The following is a description of a gene set: Any process that activates or increases the frequency, rate, or extent of cytokine production that contributes to an immune response. studied in species Mus musculus Mouse Gene Set: GOBP_POSITIVE_REGULATION_OF_CYTOKINE_PRODUCTION_INVOLVED_IN_IMMUNE_RESPONSE, and this is the list of marker genes: Rigi, Ticam1, Mavs, Tirap, Ifng, Inava, Slamf1, Card9, Klrh1, Tlr7, Malt1, Dhx36, Myd88, Cd36, Arid5a, Traf2, Cd55, Il21, Mapkapk2, Gata3, B2m, Cd55b, Clnk, Trim6, Kit, Tlr3, Laptm5, Cd226, Lacc1, Sash3, Cd160, Spon2, Traf6, Il4 (NCBI Gene Id 16189), Wnt5a, Ffar3, Casp1, Clec7a, Nod2, Nod1, Tbx21, Gprc5b, Cd81, H2-M3, Mif, Casp4, Scimp, Il18, Ddx1, Plcg2, Cd74, Il18r1, Psg22, Irf5, Tek, Nr4a3, Xcl1, Rtn4, Nlrp3, Gimap3, Syk, Fzd5 (frizzled class receptor 5), Tlr4, Tnfrsf14, P2rx7, Fcer1g, Panx1, Il6, Mir324, Map3k7, F2rl1, Ffar2, Sirt1, Il1b, Tlr2, Prkcz, Gimap5, Sema7a, Rsad2, Sphk2, Fcer1a, Dennd1b, Htr2a, Il1r1, Ripk2, H2-T23, Hk1 (NCBI Gene Id 15275), Ddx21, Tnfsf4, Pycard